Given this list of marker genes CEP152, CDC20B, DEUP1, SASS6, CCDC78, PLK4, here is a description of the gene set: A spherical, electron dense, cytoplasmic structure that is involved in de novo assembly of centrioles. Human Gene Set: GOCC_DEUTEROSOME studied in species Homo sapiens